The following is a description of a gene set: Human Gene Set: GOBP_INDOLE_CONTAINING_COMPOUND_CATABOLIC_PROCESS studied in species Homo sapiens The chemical reactions and pathways resulting in the breakdown of compounds that contain an indole (2,3-benzopyrrole) skeleton., and this is the list of marker genes: IL4I1, HAAO, TDO2, KMO, AFMID, IDO1, ACMSD, IDO2, KYNU